The following is a description of a gene set: Cytokines mediate cell-cell communication in the immune system and represent important therapeutic targets. A myriad of studies have highlighted their central role in immune function, yet we lack a global view of the cellular responses of each immune cell type to each cytokine. To address this gap, the authors created the Immune Dictionary, a compendium of single-cell transcriptomic profiles of more than 17 immune cell types in response to each of 86 cytokines (>1,400 cytokine-cell type combinations) in mouse lymph nodes in vivo. A cytokine-centric view of the dictionary revealed that most cytokines induce highly cell-type-specific responses. For example, the inflammatory cytokine interleukin-1β induces distinct gene programmes in almost every cell type. A cell-type-centric view of the dictionary identified more than 66 cytokine-driven cellular polarization states across immune cell types, including previously uncharacterized states such as an interleukin-18-induced polyfunctional natural killer cell state. Mouse Gene Set: CUI_MIGDC_IL12_RESPONSE_UP from publication Cui A, Huang T, Li S, Ma A, Pérez JL, Sander C, Keskin DB, Wu CJ, Fraenkel E, Hacohen N (PMID 38057668) studied in species Mus musculus Genes positively differentially expressed in cell type: MigDC (migratory dendritic cell) upon treatment with cytokine: IL-12 in mouse lymph nodes in vivo., and this is the list of marker genes: Srrt, Igtp, Dnajc2, Stat1, H2bc4, Irgm1